Given this list of marker genes Fgf4, Tgfbr3, Ubb, Fgf3, Fgf2, Uba52, Fgf6, Gab1, Spred2, Rps27a, Fgf20 (fibroblast growth factor 20), Ptpn11, Ubc, Ppp2ca, Fgf23, Mknk1, Gipc1, Spred1, Fgfrl1, Pik3ca, Shc1, Uba52rt, Frs3, Flrt3, Fgfr1, Fgf10, Hras, Grb2, Sos1, Flrt2, Flrt1, Plcg1, Braf (Braf transforming gene), Fgf17, Fgf18, Frs2, Cbl, Ppp2r1a, Kras, Spry2, Src, Mapk1, Fgf9, Kl, Fgf1, Mapk3, Ppp2cb, Fgf22, Fgf5, Fgf8, Pik3r1, here is a description of the gene set: Mouse Gene Set: REACTOME_SIGNALING_BY_FGFR1 species: Mus musculus Signaling by FGFR1